Given this list of marker genes Eif2b4, Atat1, Cul1, Tsr3, mt-Ts2, Ephx3, Rab14, Rpl32, Rnf111, 4930513N10Rik, Lca5l, Tlcd2, Zfc3h1, Mtrex, Zfp989 (zinc finger protein 989), Pex12, Rnf146, Vps72, Rxrb, Ighv8-14, Mtf2, Stx12, Adam23, Nepro, Trim17, Zfp74, Ubr4, Zc3hav1l, Cebpz, Rabl3, Snw1, Zfp609, Ankib1, Pde8b, Pcif1, Ift46, Mir707, Rnu11, Zzz3, Ccdc57, Mir7036b, H2ac18, Sec24a, Dnajc3, Txndc17, Eif2s1, Nol10, Dbnl, Atxn7l3b, Arf1, Snhg17 (small nucleolar RNA host gene 17), Lrrc57 (NCBI Gene Id 98759), C330018D20Rik, Cenpl, Gm28047, Cnbp, Urb1, Trip4, Caprin1, Chpf2, Zbtb37, Usp32, Atp5pb, Dars2, Chchd4, Ankfy1 (ankyrin repeat and FYVE domain containing 1), Ccdc167, Atraid, Cc2d2a, Abhd11, B4galt4, Rnf220, Abi1 (NCBI Gene Id 214715), Med18, Cryz, Mtx2, mt-Tw, Zmat5, Or9s27, Tial1, Large1, Haus2, Crat, Duxf1, Ccz1, Ep400, Rabgap1, Ubxn7, Rnf31, Itsn2, Ncor1, Tmem222, Rbm5, Atf7, Tnpo3, Bop1, A230103J11Rik (RIKEN cDNA A230103J11 gene), Tnpo1, mt-Ty, Ighv8-5, Atpaf1, Gm16184, Tmem203, Cdc37, Ppp1r7, Top2a (NCBI Gene Id 21973), Poldip2, Lin28a, Kars1, Spg11, Cpne1, Snord3a, Lyset, Tnfaip8l1, 2610005L07Rik, Hbp1, Rsrc1, Spice1, Mrps18a, Lrba, Fxr2, Msh6, Tmed5, Crebzf, Mfap3l, Atpsckmt, Vps29, Polr3b, Zfp418, Rapgef6, Gemin6, Btf3, Celf1, Timm10, Fbxl12os, Birc2, Eya3, Gtf2h4, mt-Nd5, Ppat, Dtwd1, 5033403F01Rik, mt-Co2, Arhgef2, Mrpl58 (mitochondrial ribosomal protein L58), Creld2, Gm22489, Fbxw17, Deaf1, Exog, Rps27l, Gm24298, Gm26504, Zdhhc6, Ddx5, Car7, mt-Tl2, Msantd5l, Tmem214, Cep126, Inpp4a, Man2c1os, Smg8, Rpl29 (ribosomal protein L29), Polm (NCBI Gene Id 54125), Fkbp8, Lrrc1, Nrros, Gm17435 (NCBI Gene Id 102639683), Timm44, Krit1, Fam219b, Sgf29, Hsf1, Amhr2, Tmem94, Sec61a1, 1700096K18Rik, A830018L16Rik, H4c16, Nip7 (NCBI Gene Id 76155), Casd1, Smn1, Cox10 (heme A:farnesyltransferase cytochrome c oxidase assembly factor 10), Zfp395, Mettl25, Csde1, Serp1, Gm9828, Ccdc124, mt-Tv, Taf7, Hilpda, Bmyc, Zc3h6, Kmt2a, Odr4, D030028A08Rik, Ociad1, Gar1, Sdf4, Asns, Sf3b3, Cbr4, Ythdc1, Nus1, Mir1894, Crkl, Tnni2, Mta3, Snhg15, Prkdc, Sub1, Thoc1, Gm12494, Nfyc, Ahctf1 (AT hook containing transcription factor 1), Tsen15, Aurkaip1, Pradc1, Gstz1, Entr1, 1810044D09Rik, Nsmce4a, Eif2a, Sycp2, Dctn4, Chic2, Ndufaf1, Nedd8, Zfp322a, Cul5, Naa25, Gm13771, Slc25a16, Gm10222, H2bc26, Tgs1, Hnrnpc, Septin7, Pask, Il7, Zfp383, Kbtbd4, Pgap3, Rps6ka5, Snrnp48, Gramd1a, Prrc2a, 4930540M05Rik, Tbc1d2, Mrpl20, 1700123O20Rik, Ivns1abp, Mme, Gtpbp4, Tmem129, Nutf2 (NCBI Gene Id 68051), Eef1akmt1, Kbtbd12, Gtf2e1, 4930520O04Rik, Adam10, 4930477O15Rik, Rmnd5a, Styk1, Cbx5, Gm22417, Cdca8, Rangap1, Mir6541, St6galnac2 (NCBI Gene Id 20446), Aen, Kmt5b, Frs3, Zfp36l1-ps, Mmrn2, Arih2, Tubgcp3, Faf2, Hmgb1, Ap1g1, 6820431F20Rik, Prim1, Abraxas1, Aldh7a1, Med13, Cdiptos (CDIP transferase, opposite strand), Gm23143, Prpf39, Tcf25, Smarca5, Lrguk, Tyw5, Asxl2, Gm13228, Nek9, Foxred1, Zfp422, Stx16, N6amt1, Ccdc61, Caprin2, Cdipt (CDP-diacylglycerol--inositol 3-phosphatidyltransferase), Spag4, Zfp229, Slc39a1, Ndufs7, Usp53 (NCBI Gene Id 99526), Ap3m1, Gstcd, Rtel1, 4930578M01Rik, Knl1, Aspa, Zfp61, Scaf8, Msrb2, Rtn4, Crls1, Morc3, Spdl1, Qrich1, BB218582, Dhodh, Mindy3, Dbr1, Ahi1, Gm26533, Timd6, Tmem43, Nae1, Rusc2, Nsun7, Acbd3, Rnf227, St3gal5, Cyb5d2 (NCBI Gene Id 192986), Mtus1 (NCBI Gene Id 97469), Mrpl22, Rce1, Cdc42, Epha7, Dnajc16, Xpo1, Ap2b1, Gm9245, Taf4b, Ddx47, Mturn, Ckap2l, Dnajb4, Arhgef1, Ccdc18, Tox, Lcmt2, Atp6v0a2, Gfpt1, Hps5, Mettl9, Sar1b, Blmh, Gle1, Pard3, Mettl3 (NCBI Gene Id 80554), 9330151L19Rik, Fam162a, Hmbox1, Epm2aip1, Safb, Kctd5, Ywhae, Eprs1, Mms22l, Alg5, Raf1, Ckap2, Rps4l, Gm15564, Ints6, Wdr26, Zbtb6, Pop7, Srsf1, Rpl9, Ipo9, Nsf, Tasor, Sfr1, Parl, Vcl, Snord13, Ncaph, Hscb, Gm22589, Ttk, Dctn5, Atxn1, Gm19569, Cops7b, Trmt61b (NCBI Gene Id 68789), Vpreb1a, 2610035D17Rik, Gm25919 (NCBI Gene Id 115486202), Mttp, Pemt, Atp6v1d, H6pd, mt-Td, Zfp27, Vegfd, Ttc13, Usp37, Jmjd4, Sgo2a, Rraga, Rrp1, Snora9, 6720482G16Rik, Sec62, Paip2b, Slc25a12, Ube2z, Canx (NCBI Gene Id 66219), Dock4, Ppil4, Tmem185b, Mcm4, Cpsf1, Cyb5r1, Rad50 (NCBI Gene Id 19360), Gpalpp1, Gm10709, Polr2m, Pdlim1, Park7, Tbc1d22a, Itprid2, Rbl1, Zfp110, Sema4b, Hint2, Khdc4, Ctps1, Chmp7, Ptprm, 1700039M10Rik, Sim1, Anp32a, Ttc27 (tetratricopeptide repeat domain 27), Cux2, Adamts19, Rfx7, Mir7648, Arhgap33os, Mrpl45, Ccn2, Bltp3b, Gm15473, Rdm1, Anapc10, Gpx1, Add1, Hnrnpd, Mfsd1, Pnpt1, Tmem242, 1600014C10Rik, Man2c1, Gm16083, Tti2, Zbp1, Ube2k, Atl2, Pigq, Gm15559, Pnldc1, Gm6089, Dnajc13 (NCBI Gene Id 546159), Shmt1, Tmem68, Gm26224, mt-Tq, Ppic, Srgap2, Paics, Tcp1, Slc5a6, Cenpw, 2810001G20Rik, Rpl10-ps6, Dhx15, Ipo8, Pld1 (NCBI Gene Id 99508), Ttc14, Srpra, Pold3, Gm5703, Uqcr10, Snrpg, Pigs, Pex13, Gm6004, Bud31, Prdx1, Zfp937, Tmem38b, Atp6v0a1, Rpl14, Cks1brt, Hebp2, Gpr161, Sdhd, Dhx29, 5033430I15Rik, Bnip3l, Rad9b, Spart, Mapkapk5, Rbm20, Mrps6, Alkbh1, Btbd9, Esyt2, Sncg, Esco1, Rsrc2, Mfap3, Duxf4, Tars2, Mak16, Ccdc127, Rpain, Calm3, Taf6, Polg2, Mrps18b (NCBI Gene Id 96968, mitochondrial ribosomal protein S18B), Smarce1, Akirin2, Ppp1r10, Shcbp1, Nufip1, Mucl2, Rab30, 5930411N13Rik, Rab23, Guca2a, 4933429H19Rik, Rnf121, Tes, Adal, Stam, Lsm4, Arhgap11a, Tamm41, Tmem208, Lias, Tmem80, Ddx42, Chd2, Ddx39b, Nsun2, Dynll1, Thg1l, Pstk, Nabp2, Gspt1, Gin1, Myo5a, Tube1, Hps3, Lexis1, Cog4, Mdp1, Agbl5, Mef2c (NCBI Gene Id 71350), Zyg11a, Msantd2, Acat1, Pole4, Gm13414, Nat10, Usp14, Rmi1, Ppih, Slc25a20, Wdr77, Schip1 (NCBI Gene Id 30953), Map7d1, Rnf6, Mier1, Prr7, Tars1, Gpr155, Thada, Atg10, Orc2 (NCBI Gene Id 98596), Snap47, Vcpkmt, Fam227b (NCBI Gene Id 75823), mt-Th, Gm6288, Prkca, Zfp207, Bscl2 (NCBI Gene Id 67517), Farsa, Vti1a, 1700074A21Rik, Smim14, mt-Tl1, Cd55, Zfp26, Piezo2, Gm18492, Borcs7, Maip1, Kmt2d, Fancl, Fgd6, Gm17089, Atrip, Nup88, Tomm6, Cep95, Scp2, Prxl2b, Palb2, Nsa2, Gmeb2, Kat6a, Nras, Rps15a-ps1, Rpn2, Mettl26, Vps54, Sdf2, Calm2, Gm22973, Cplane2, Bach2, Nenf, Slc39a7, Tpmt, C230035I16Rik, Gfm2 (G elongation factor, mitochondrial 2), Tatdn3, B3galt4, Slx4ip, Gm10518, Atp5mg, Mpnd, Lrrfip1 (leucine rich repeat (in FLII) interacting protein 1), Glrx2, AU041133, Mis18bp1, H2ac25, Tomm70a, Gm10735, Pigt, Dclre1b, Zfp866, Slc5a3, Gm15545, Pex19, Mrpl11, Tmcc1, Psmb1, Mrpl32, Atp6v1b2, Pum1, Ilf2, Rptor, Rpl23, Hnrnpk, Stx18, Serbp1, Gm13033, Tacc3 (transforming, acidic coiled-coil containing protein 3), Shld1, Pex2, Khdrbs1, Prdm15 (NCBI Gene Id 353037), Akt1s1, Denr, Ccdc15, Oasl1, Stimate, Gm15834, Gtf3c6, Elf2, Ate1, Rpap1, Commd2 (COMM domain containing 2), Zscan21, Slc35e1, Slc35b3, Copz1, mt-Rnr2, C030034I22Rik, Fam114a2, Csnk1g1, Mybbp1a, 1110002L01Rik, Airim, Cnpy4, Wdr43, Eef1g, 9130604C24Rik, Dot1l, Mrpl18, Pimreg, Snora21 (NCBI Gene Id 100302498), Cct5, Ccdc107, Dek, Ints12, Hus1, Pvr, U2af1, Eapp, Rxylt1, Gm14023, Map9, Wscd1, Tmem199, Calm1, Vangl1, Alas1, Ube2q2, Top3b, Chek2, Atp5f1a (NCBI Gene Id 52533), mt-Nd1, Zbtb17, Snora7a, Mindy1, Slc13a4, Odf2, Adgrl2, Mcm6, Wbp4, Rala, Zbtb18, Ssbp1, Poldip3, Zfp771, Rbsn, Pdss2, Gm10433, Zfp444, Ptcd2, Zzef1, Pdap1, D230022J07Rik, Tpi1, Jtb, Psma2, Poglut3, Chaserr, Washc2, Fbxl9 (NCBI Gene Id 234684), Rmrp (RNA component of mitochondrial RNAase P), Ing3, Gtf2h1, Nabp1, Tmem101, Thap2, Kansl1, Mapk1, Gls, Aebp2, Mtg1, Gosr1 (NCBI Gene Id 53879), Zfp992, 2510002D24Rik, Mkks, Lmln, Gm3242, Calcoco2, Kdm3a, Epha2, Fbxw2, Cnot9, Cldn9, Snx17, Plekhg2, Ndufs3, Steap3, Kdm1b, Zfr, Pus10, Adck1, Sdha, Thnsl1, Meaf6, Gm13146 (NCBI Gene Id 384087), R3hcc1l, Nsl1, Dctn6, Mipol1, Utp25, Maml1 (mastermind like transcriptional coactivator 1), Slc35e2, Rnf41, Xntrpc, Thumpd1, Polr2d, Vipr1, Ubxn8, Wdr95, Nkiras2, Ndufc1, Sucla2, Prkrip1, Acin1, Cdkn2aip, Gm17767, Ube2v2, Atad2, Sco1, Tcerg1, Gm12428, Usp40, Atf7ip, Mtln, 9230114K14Rik (RIKEN cDNA 9230114K14 gene), Prpf3, Ccnl2, Gm16124, Rad52, Eif4g2, Cntnap2, Zdhhc17, Ctdnep1, Adam1b, Gm13223, Srd5a1, Armc8, Ppp2ca, Bsdc1, Sumo2, Cops3, Vmn2r90, 4933427D14Rik, Sox2ot, Fbxl3, Nptx2, Abcg2, Mroh8, Ufl1, Ccnb2, Gm13830, Snhg5, Ccdc59, Pold4, Dclre1a, Eif5, Virma, Gm13034, Golga1, Nasp, Terf2ip, Gm22357, Alg12, Mrps12, Uqcrc1, Plce1, Trappc4 (NCBI Gene Id 80545), Usp34, Dync1li1, Iars2, 4931415C17Rik, Ctnna1, Gm17509, Atrx, Fam229b, Dtd2, Zfp882, Rfx8, Pmpca, Mir6236, Tbrg1, Vps33a (VPS33A CORVET/HOPS core subunit), Cib2, Srrm2, Nup50, Ndufaf7, Wdr41, Fbxl5, Tcea2, Ramacl, Zfp994, Ndor1, Pdcd7, Cfap97, Rnf38, Brix1, Sars2, Tpr, Cnot2, Strn3, Tbc1d15, Dcun1d4, Mtfr2, Wtap, Vezt, Gm8357, Rab3gap2, Pakap, Fkbp1a, Mir8120, Ezh2, Cfap157, Ubr1, Cxxc4, Zfp985, Safb2, 4930532G15Rik, Elp5, Camk4 (calcium/calmodulin-dependent protein kinase IV), Zfat, Rnu12, Ptpdc1, 4930509E16Rik, Enkur, D8Ertd738e, Prmt5, Rnft1, Ccdc47, Stamos, Wdr4, Ighv1-67, Ppm1g, Syngr1, Ap4b1, Dnajc7, Zhx2, Ppp4r1, Rgs5, Tbc1d17, Prkacb, Dynlt1b, Pik3r4, Mir22hg, Septin11, Stap2, Ankle2, Thoc3, Cdk5rap3, Tnks, Gm14167, Osgin2, Xndc1, Mir1983, Psme2, Dhx37, Nudt1, mt-Tc, Cnga1, Aldh3a2, Slirp, Kansl3, Duxf3, Frg2f1 (NCBI Gene Id 433752), Cdc42bpa, Kdm4d, Clpb, Foxj3, Rfx3, Cnnm3, Gas5, Gm5067, Zfp81, Myzap, Sfi1, Spaca6, Trmt10a, Rbm12, Dip2b, Mrps27, Hint3, Ctsd, Ing5, Srrt, Camta1, Selenoi, Zfp809, Sergef, Prdm9, Mras, 4930500F10Rik, Ccdc13, Mcph1, Tox4, Atp13a4, Cog8, Ginm1, Mrm2, Mir7668 (microRNA 7668), Gba1, Phkg1, Kntc1, Akap1, Rad1, Hnrnph1, Adprm, Ttpal, Mir8111, Gm13162, Ank1, Exosc8, here is a description of the gene set: studied in species Mus musculus Genes containing one or more binding sites for (Ruvbl1) in their promoter regions (TSS -1000,+100 bp) as identified by GTRD version 20.06 ChIP-seq harmonization. Mouse Gene Set: RUVBL1_TARGET_GENES from publication Yevshin I, Sharipov R, Kolmykov S, Kondrakhin Y, Kolpakov F (PMID 30445619)